Given this list of marker genes ADARB1, ADAR, here is a description of the gene set: part of: mRNA Editing: A to I Conversion Reactome Pathway: C6 deamination of adenosine studied in species Homo sapiens Hydrolytic deamination of adenosine leads to inosine. Ammonia is presumed to be released during this reaction.<BR>